Given this list of marker genes IFNA8, SOCS1, IFNA17, STAT1, PTPN6, IFNA5, JAK1, IFNAR1, IFNA21, IFNA6, TYK2, STAT2, USP18, IFNA4, IFNB1, IFNA1, SOCS3, IFNAR2, IFNA2, PTPN11 (NCBI Gene Id 84990), IFNA7, IFNA14, IFNA16, IFNA10, PTPN1 (NCBI Gene Id 5770), here is a description of the gene set: There are several proteins and mechanisms involved in controlling the extent of ligand stimulation of IFNA/B signaling. These mechanisms can effect every step of the IFNA/B cascade. Dephosphorylation of JAK and STAT by SHP protein phosphatases, inhibition of STAT function in the nucleus by protein inhibitors of activated STATs (PIAS) proteins, inhibition of tyrosine kinase activity of JAKs by SOCS as well as inhibition of JAK and IFNAR2 interaction by UBP43 are few of the negative regulation mechanisms in controling type I IFN signaling. part of: Interferon alpha/beta signaling Reactome Pathway: Regulation of IFNA/IFNB signaling studied in species Homo sapiens